Given this list of marker genes ACTA2, DDR2, MYB, RPS6KA1, LEP, GCLC, CYGB, here is a description of the gene set: Human Gene Set: GOBP_REGULATION_OF_HEPATIC_STELLATE_CELL_ACTIVATION species: Homo sapiens Any process that modulates the frequency, rate or extent of hepatic stellate cell activation.